Given this list of marker genes EMILIN1, FBLN1, MFAP5, EFEMP2, GDF5, BMP4, TGFB2, FBN1, LTBP2, LOXL3, FBLN2, ITGA8, LTBP4, LOXL2, FURIN, FBLN5, ITGB8, ITGB3, MFAP3, LTBP3 (latent transforming growth factor beta binding protein 3), ITGB1, MFAP2, ITGA5, ITGB6, LOXL1, VTN, LOX, ITGAV, LOXL4, MFAP4, EMILIN3, FN1, ITGB5, ELN, BMP2, TGFB3, TGFB1, EMILIN2, LTBP1, BMP7, BMP10, EFEMP1, FBN2 (fibrillin 2), FBN3, here is a description of the gene set: Reactome Pathway: Elastic fibre formation species: Homo sapiens part of: Extracellular matrix organization Elastic fibres (EF) are a major structural constituent of dynamic connective tissues such as large arteries and lung parenchyma, where they provide essential properties of elastic recoil and resilience. EF are composed of a central cross-linked core of elastin, surrounded by a mesh of microfibrils, which are composed largely of fibrillin. In addition to elastin and fibrillin-1, over 30 ancillary proteins are involved in mediating important roles in elastic fibre assembly as well as interactions with the surrounding environment. These include fibulins, elastin microfibril interface located proteins (EMILINs), microfibril-associated glycoproteins (MAGPs) and Latent TGF-beta binding proteins (LTBPs). Fibulin-5 for example, is expressed by vascular smooth muscle cells and plays an essential role in the formation of elastic fibres through mediating interactions between elastin and fibrillin. In addition, it plays a role in cell adhesion through integrin receptors and has been shown to influence smooth muscle cell proliferation. EMILINs are a family of homologous glycoproteins originally identified in extracts of aortas. Found at the elastin-fibrillin interface, early studies showed that antibodies to EMILIN can affect the process of elastic fibre formation. EMILIN1 has been shown to bind elastin and fibulin-5 and appears to coordinate their common interaction. MAGPs are found to co-localize with microfibrils. MAGP-1, for example, binds strongly to an N-terminal sequence of fibrillin-1. Other proteins found associated with microfibrils include vitronectin.<br><br>Fibrillin is most familiar as a component of elastic fibres but microfibrils with no elastin are found in the ciliary zonules of the eye and invertebrate circulatory systems. The addition of elastin to microfibrils is a vertebrate adaptation to high pulsatile pressures in their closed circulatory systems. Elastin appears to have emerged after the divergence of jawless vertebrates from other vertebrates. <br><br>Fibrillin-1 is the major structural component of microfibrils. Fibrillin-2 is expressed earlier in development than fibrillin-1 and may be important for elastic fiber formation. Fibrillin-3 arose as a duplication of fibrillin-2 that did not occur in the rodent lineage. It was first isolated from human brain.<br><br>Fibrillin assembly is not as well defined as elastin assembly. The primary structure of fibrillin is dominated by calcium binding epidermal growth factor like repeats. Fibrillin may form dimers or trimers before secretion. However, multimerisation predominantly occurs outside the cell. Formation of fibrils appears to require cell surface structures suggesting an involvement of cell surface receptors. Fibrillin is assembled pericellularly (i.e. on or close to the cell surface) into microfibrillar arrays that undergo time dependent maturation into microfibrils with beaded-string appearance. Transglutaminase forms gamma glutamyl epsilon lysine isopeptide bonds within or between peptide chains. Additionally, intermolecular disulfide bond formation between fibrillins is an important contributor to fibril maturation.<br><br>Models of fibrillin-1 microfibril structure suggest that the N-terminal half of fibrillin-1 is asymmetrically exposed in outer filaments, while the C-terminal half is buried in the interior. Fibrillinopathies include Marfan syndrome, familial ectopia lentis, familial thoracic aneurysm, all due to mutations in the fibrillin-1 gene FBN1, and congenital contractural arachnodactyly which is caused by mutation of FBN2 (Maslen & Glanville 1993, Davis & Summers 2012).<br><br>In vivo assembly of fibrillin requires the presence of extracellular fibronectin fibres. Fibrillins have Arg-Gly-Asp (RGD) sequences that interact with integrins and heparin-binding domains that interact with a cell-surface heparan sulfate proteoglycan possibly a syndecan. Fibrillins also have a major role in binding and sequestering growth factors such as TGF beta into the ECM. Proteoglycans such as versican, biglycan, and decorin can interact with the microfibrils. They confer specific properties including hydration, impact absorption, molecular sieving, regulation of cellular activities, mediation of growth factor association, and release and transport within the extracellular matrix. In addition, glycosaminoglycans have been shown to interact with tropoelastin through its lysine side chains, regulating tropoelastin assembly (Tu & Weiss 2008).<br><br>Elastin is synthesized as a 70kDa monomer called tropoelastin, a highly hydrophobic protein composed largely of two types of domains that alternate along the polypeptide chain. Hydrophobic domains are rich in glycine, proline, alanine, leucine and valine. These amino acids occur in characteristic short (3-9 amino acids) tandem repeats, with a flexible and highly dynamic structure. Unlike collagen, glycine in elastin is not rigorously positioned every 3 residues. However, glycine is distributed frequently throughout all hydrophobic domains of elastin, and displays a strong preference for inter-glycine spacing of 0-3 residues. <br><br>Elastic fibre formation involves the deposition of tropoelastin onto a template of fibrillin rich microfibrils. Recent results suggest that the first step of elastic fiber formation is the organization of small globules of elastin on the cell surface followed by globule aggregation into microfibres. An important contribution to the initial stages assembly is thought to be made by the intrinsic ability of the protein to direct its own polymeric organization in a process termed 'coacervation'. This self-assembly process appears to be determined by interactions between hydrophobic domains which result in alignment of the cross-linking domains, allowing the stabilization of elastin through the formation of cross-links generated through the oxidative deamination of lysine residues, catalyzed by members of the lysyl oxidase (LOX) family. The first step in the cross-linking reaction is the oxidative formation of the delta aldehyde, known as alpha aminoadipic semialdehyde or allysine. Subsequent reactions that are probably spontaneous lead to the formation of cross-links through dehydrolysinonorleucine and allysine aldol, a trifunctional cross-link dehydromerodesmosine and two tetrafunctional cross-links desmosine and isodesmosine (Lucero & Kagan 2006), which are unique to elastin. These cross-links confer mechanical integrity and high durability. In addition to their role in self-assembly, hydrophobic domains provide elastin with its elastomeric properties, with initial studies suggesting that the elastomeric propereties of elastin are driven through changes in entropic interactions with surrounding water molecules (Hoeve & Flory 1974). <br><br>A very specific set of proteases, broadly grouped under the name elastases, is responsible for elastin remodelling. The matrix metalloproteinases (MMPs) are particularly important in elastin breakdown, with MMP2, 3, 9 and 12 explicitly shown to degrade elastin (Ra & Parks 2007). Nonetheless, elastin typically displays a low turnover rate under normal conditions over a lifetime.